The following is a description of a gene set: Marker genes curated from the annotated cluster as represented in the Descartes Human Gene Expression During Development database. The gene expression program underlying the specification of human cell types is of fundamental interest. The study authors generated human cell atlases of gene expression and chromatin accessibility in fetal tissues. For gene expression, the study authors applied three-level combinatorial indexing to >110 samples representing 15 organs, ultimately profiling ~4 million single cells. The study authors leveraged the literature and other atlases to identify and annotate hundreds of cell types and subtypes, both within and across tissues. Our analyses focused on organ-specific specializations of broadly distributed cell types (such as blood, endothelial, and epithelial), sites of fetal erythropoiesis (which notably included the adrenal gland), and integration with mouse developmental atlases (such as conserved specification of blood cells). These data represent a rich resource for the exploration of in vivo human gene expression in diverse tissues and cell types. Human Gene Set: DESCARTES_FETAL_LIVER_MYELOID_CELLS species: Homo sapiens from publication Cao J, O'Day DR, Pliner HA, Kingsley PD, Deng M, Daza RM, Zager MA, Aldinger KA, Blecher-Gonen R, Zhang F, Spielmann M, Palis J, Doherty D, Steemers FJ, Glass IA, Trapnell C, Shendure J (PMID 33184181), and this is the list of marker genes: TMEM63C, IFIT2, MMP2-AS1, C9orf72, SLC29A3, HRH1, IFI27, SIRPB2, KCNMA1, ADGRE1, THEMIS2, FMN1, TNFAIP8L2, CYBB, SEZ6L, ENSG00000258168, TRIM36, FCGR3A, AGBL4-IT1, CLEC4F (C-type lectin domain family 4 member F), VCAM1, CD1C, FUCA1, HMOX1, MS4A4E, CD209, CABP4, NOD2, RGS1, C1QB, DMXL2, NAPSB, SIGLEC16, MS4A4A, NABP1, CD5L, LILRB1, FGL2, CCDC170, TMEM26-AS1, CD163, CFD, CCR1, PLBD1, DHDH (dihydrodiol dehydrogenase), CD300LF, LINC02057, C1orf162, CPVL, IDO1, LRRC25, IFIT3, MARCHF1, CSF1R, LILRB4, LINC00970, IL10RA, AXL, PDE1B, LHCGR, TLR5, MX2 (NCBI Gene Id 4600), SEPTIN9-DT, MANCR, NFAM1, SIGLEC9, ENSG00000258039, SLC15A3, IGSF21, ADAP2, TMEM86A, RNASE6, CETP, GFRA2, KCNJ10, MSR1, RAB39A, CREG1, TPRG1, FPR1, TYROBP, ENSG00000227531, CCR3, TLX1, LINC01504, LINC01645, TLDC2 (NCBI Gene Id 343574), HK3, MYO7B (myosin VIIB), LILRA6, PLA2G15, LILRA5, EPB41L3, PDCD1LG2, SPIC, LILRB3, CMKLR1, PHKA1, SEMA4A, RNF135, SLC31A2, LGMN, SIGLEC7, NCF2, SLC49A4, SDC3, TBC1D30, FCN1, PDK4, CARD14, GPR137B, IGSF6, BATF3, EBI3, LILRA1, SPSB4, SIGLEC11, CST3, GAA (NCBI Gene Id 2548), ITGAX, TNFAIP2, ADGRE4P, CALHM6, DOCK8-AS1 (DOCK8 antisense RNA 1), PLBD1-AS1, CXCR2P1, SLC37A2, RAB31, FCGR2C, TMIGD3, LINC02345, NFKBIE, CTSB, TYMP, HLA-DQA1, LINC03070, CD68, CSF2RA, RGL3, SCIMP, CD86, P2RY13, RASSF4, CDH13-AS2, SIGLEC14, C3AR1, RBM47, C1QC, OTULINL, MARCO, KCNAB1 (NCBI Gene Id 7881), EYA2, NDST3, NLRC4, TLR8, CXCL9, TIMD4, AGBL4, SIGLEC1 (NCBI Gene Id 6614), LILRB5, TNFRSF11A, VSIG4, FPR3, OLFML2B, CTSS, RN7SL138P, CFP, SIGLEC5, PTPRO, FCAR, PLA2G7, HORMAD1, OSCAR (osteoclast associated Ig-like receptor), SMIM35, NEXMIF, C1QA, IL4I1, SLC24A4, CXCL10, LILRB1-AS1, SAMHD1, LINC03122, ENSG00000253557, MCOLN1, FOLR2, OSBPL11, LILRB2, CD80, SIRPB1, TBX1, PILRA, MAFB, KCNK13, P2RY6, ME1, GPBAR1, SUCNR1, RASGEF1C, PLPP2, MERTK, PELATON, CLEC7A, CD163L1, LIPA, SCN1B, CXCL8, MPEG1, MS4A14, IFNGR1, FGD2, MS4A7, ELF5